Given this list of marker genes SCNN1B, DNAAF4, CFAP221 (NCBI Gene Id 200373), DNAAF5, STX1A, MFAP5, NME5, MAT2A, DNAAF2, GAS2L2 (NCBI Gene Id 246176, growth arrest specific 2 like 2), IL12B, TLR4, NME8 (NME/NM23 family member 8), TGFBR1, DNAI1 (NCBI Gene Id 3393), SPAG1, DNAAF11, TGFB1, DNAH9, RSPH4A, MCIDAS, OFD1, MLX, SMAD4, HFE, CTLA4, GIMAP5, LRRC56 (NCBI Gene Id 115399), PRTN3, IL12A, DNAH1, MYLK, ENG, ODAD2, TLL1, DNAI2, CCDC39, STK36, ODAD1, DNAH5, STAT4 (NCBI Gene Id 6775), IL17RC, HYDIN, SERPINA1, IFNG, IL17RA, CCNO, SMAD3, THSD4, CFTR (NCBI Gene Id 1080), RSPH3, SLC34A2 (NCBI Gene Id 153010), IL10, F5, CFAP298, DNAH11, BTNL2, DRC1, SCNN1G, RSPH1 (radial spoke head component 1), CFAP74 (NCBI Gene Id 93196), FOXJ1, IFNGR1, DNASE1L3, GDF2, SLC26A9, MYH11, HEY2, RSPH9, CFAP300, ARPC5 (actin related protein 2/3 complex subunit 5), HLA-B, DNAJB13, RPGR, ERAP1, EIF2AK4, SLC11A1, TSC2, TSC1, CLEC7A, HLA-DPA1, SCNN1A, ODAD3, PRKG1, FBN1, NEK10, KLRC4, DCTN4 (dynactin subunit 4), TGFB3, DNAAF3, GCLC, ELN, ZMYND10, SPEF2, COL3A1, DNAL1, IL23R, IL17F, CCR1, SLC9A3, SMAD2, CEACAM3, HLA-DRB1, CCDC40, TRAF3IP2, LOX, ODAD4, GSTM3, DNAAF1, TGFB2, ACVRL1, COL5A1, FAS, SLC6A14, FOXE3, CEACAM6, IL12A-AS1, PTPN22, FCGR2A, HMOX1, CLCA4, TTC12, TGFBR2, ACTA2, MIF, KCNN4, UBAC2, EDNRA, C4A, DNAAF6, HLA-DPB1, MEFV, COL5A2 (collagen type V alpha 2 chain), here is a description of the gene set: Abnormal appearance of material expectorated (coughed up) from the respiratory system and that is composed of mucus but may contain other substances such as pus, blood, microorganisms, and fibrin. Human Gene Set: HP_ABNORMAL_SPUTUM species: Homo sapiens Abnormal sputum